Given this list of marker genes Pear1, Gp1bb, Tlr4, Gp5, Selp, Gp9, Flna, Gp1ba, Plek, Pla2g4a, Ptprj, Pdpn, Svep1, Jak2, here is a description of the gene set: Any process that increases the rate or frequency of platelet activation. Platelet activation is a series of progressive, overlapping events triggered by exposure of the platelets to subendothelial tissue. Mouse Gene Set: GOBP_POSITIVE_REGULATION_OF_PLATELET_ACTIVATION species: Mus musculus